The following is a description of a gene set: Any process that modulates the frequency, rate or extent of a process involved in the formation, arrangement of constituent parts, or disassembly of a microvillus. Mouse Gene Set: GOBP_REGULATION_OF_MICROVILLUS_ORGANIZATION studied in species Mus musculus, and this is the list of marker genes: Cdhr2, Klf5, Cdhr5, Fscn1, Vil1, Pls1, Ush1c, Pld1, Podxl, Ezr, Twf2, Hnf4a, Rap1gap, Atp8b1, Prl2c2